The following is a description of a gene set: The multiplication or reproduction of smooth muscle cells, resulting in the expansion of a cell population. studied in species Mus musculus Mouse Gene Set: GOBP_SMOOTH_MUSCLE_CELL_PROLIFERATION, and this is the list of marker genes: Xbp1, Jun, Frs2, Nppc, Prkdc, Edn1, Pde4d, Cyba, Sod2, Hmgcr, Itga2, Abcc4, Tacr1, Alox12, Mtor, Mir145a, Bmp2, Nol3, Nr4a3, Gsk3b, Aif1, Il6, Rbpms2, Il10, Ace2, Pparg, Ern1, Gper1, Vegfa, Pik3ca, Cnn1, C3ar1 (complement component 3a receptor 1), Cdh13, Cav1, Igf1, Pdgfb, Ptk2, Map3k5, Gna13, Trib1, Myb, Ppargc1a, Nampt, Il12b, Notch3, Ptgis, Ang2, Elane, Pdgfd, P2ry6, Tnfaip3, Pak1, Nox1, Ang6, Poldip2, Vipr2, Il6ra, Ndrg2, Ptafr, Src, Phb1, Igfbp3, Ogn, Gnai2, Foxp1, Rbm10, Ndrg4, Pdgfrb, Akt1, Cx3cl1, Prkca, Stat1, Ang, Grk2, Il18, Prkg1, Esr2, Camk2d, Tcf7l2, Gstp1, S1pr1, Agt, Ptgs2, Hes5, Ang4, Irak4, Mir143, Enpp1, Ccl5, Spon2, Bmp4, Igf1r, Mmp2, Htr1b, Apod, Mnat1, Hmox1, Mdm2, Hpgd, Shc1, Bmpr1a, Esr1, Sulf1, Ccn3, Igfbp5, Efemp2, Mef2c, Nos3, Gnai3, Trp53, Stat5b, Gna12, Nppb, Drd4, Smpd3, Mir504, Rhoa, Park7, Fgf2, Traf6, Mmp9, Myocd, Hbegf, Adamts1, Tpm1, Serpinf2, Ccn4, Ptgir, Nf1, Cdkn1b, Mfn2, Tgfb1, Skp2, Tgfb3, Tgm2, Klf4, Adipoq, Mef2d, Xrcc5, Agtr1a, Retn, Pdcd4, Naa35, Tgfbr2, Il13, Dnmt1, Ddit3, Ang5, Npr1, Il12a, Mir124a-1hg, Myc, Gstp2, Hdac4, Gnaq, S1pr2, Ednra, Npy5r, Foxj2, Orc1, Xrcc6, Ctnnbip1, Cdkn1a, Kcnn4, Tafa5, Jak2 (NCBI Gene Id 98155), Gja1, Tert, Tnf, Map3k7, Npr3, Comt, Calcrl, Fgf9, Bmpr2, Tlr4, Dbh, Sf1, Pde1a, Vip, Flt1, Nqo2, Rgs5, Zfp143, Rps6kb1, Itgb3, Ifng, Ctnnb1, Timp3, Ldlrap1, Pik3r1, Id2, Irak1, Ilk, Hif1a, Egr1, Ppard, Ddx39b, Ager, Ereg, Pten, Akr1b1, Egfr, Ddr2, Apln, Myd88, Apoe, Thbs1, Il15, Fgfr2